Given this list of marker genes SLC34A2, SLC20A2, SLC34A3, SLC34A1, SLC20A1, here is a description of the gene set: Sodium-coupled phosphate cotransporters Human Gene Set: REACTOME_SODIUM_COUPLED_PHOSPHATE_COTRANSPORTERS species: Homo sapiens